The following is a description of a gene set: from publication Toyota M, Suzuki H, Sasaki Y, Maruyama R, Imai K, Shinomura Y, Tokino T (PMID 18519671) Altered expression of microRNA (miRNA) is strongly implicated in cancer, and recent studies have shown that, in cancer, expression of some miRNAs cells is silenced in association with CpG island hypermethylation. To identify epigenetically silenced miRNAs in colorectal cancer (CRC), we screened for miRNAs induced in CRC cells by 5-aza-2'-deoxycytidine (DAC) treatment or DNA methyltransferase knockout. We found that miRNA-34b (miR-34b) and miR-34c, two components of the p53 network, are epigenetically silenced in CRC; that this down-regulation of miR-34b/c is associated with hypermethylation of the neighboring CpG island; and that DAC treatment rapidly restores miR-34b/c expression. Methylation of the miR-34b/c CpG island was frequently observed in CRC cell lines (nine of nine, 100%) and in primary CRC tumors (101 of 111, 90%), but not in normal colonic mucosa. Transfection of precursor miR-34b or miR-34c into CRC cells induced dramatic changes in the gene expression profile, and there was significant overlap between the genes down-regulated by miR-34b/c and those down-regulated by DAC. We also found that the miR-34b/c CpG island is a bidirectional promoter which drives expression of both miR-34b/c and B-cell translocation gene 4 (BTG4); that methylation of the CpG island is also associated with transcriptional silencing of BTG4; and that ectopic expression of BTG4 suppresses colony formation by CRC cells. Our results suggest that miR-34b/c and BTG4 are novel tumor suppressors in CRC and that the miR-34b/c CpG island, which bidirectionally regulates miR-34b/c and BTG4, is a frequent target of epigenetic silencing in CRC. Genes down-regulated in HCT116 cells (colon cancer) upon expression of MIR34B or MIR34C microRNAs. species: Homo sapiens Human Gene Set: TOYOTA_TARGETS_OF_MIR34B_AND_MIR34C, and this is the list of marker genes: FAM234B, RIF1, CKAP2L, CASKIN2, RAD51, PPP6R2, ZMYND19, SPDYE3, CSPP1, ADISSP, C6orf89, METTL15, HSPD1, HPCA, MPHOSPH9, CHST12, FOXRED1, KRIT1, NUP58, PRKAG1, DCLRE1C, PPIP5K1, PRPF19, MBOAT2, PHTF2, MAPT, ARL13B, TMEM18, HMGN4, CENPE, BCCIP, SNU13, DPY19L1P1, CWC25, PARPBP, RFC3, DDX39B, NAV1, CNPY3, TEF, SRSF10, HDAC8, NEDD1, HYLS1, TCF7L2, STRBP, DENND5B, CDCA7, GALNT11, RAB3D, KLHL23, SLC7A11 (solute carrier family 7 member 11), ZNF681, ALMS1, C2CD2, ARHGAP11A, FEN1, RFXAP, TEX261 (NCBI Gene Id 113419), ARID1A, RTKN2 (rhotekin 2), NCOR1, SNORD22, ZNF695, SUV39H1, SREK1IP1, WDR36, RFC2, MELK, TRMT61A, HCN3, SHQ1, CCNA2, FAR1, POP1, NUFIP1, ZC3H13, KMT5A (NCBI Gene Id 387893), PLK1, MUSTN1, SHLD2, HAUS6, GRK3, SAMD1, XRCC2, TSR2, TFDP1, TAGLN2, MTARC1, MET, HOOK1, CENPF, JADE1, SRSF4, ATAD5, MSH5, TNPO3, ATPSCKMT, MIS18A, ANP32B, SF1, PPARGC1B, AFG3L2, ABHD2, SLC35A4, RAN, KAT7, MTERF2, PHLDB2, RIOK1, HNRNPA3, FAR2, LHFPL2, BARD1, CENPJ, MSL1, CEP72, HDAC6, SLC16A14, TMEM200B, EIF2S2, API5, TRIP13, CDK4 (cyclin dependent kinase 4), PRR22, MED28, CEP152, HNRNPUL1, POLR1E, L2HGDH, FIGNL1, DBF4B, RAVER2, RAD54L2, TNFRSF21, TMED4, LUC7L, CMTM1, BRI3BP, RAD54L, AURKB, DIDO1, BUB1B, SKA1, UNG, KLHDC4, ADCK2, KIF15, FAM81A, RAB31, MYB, PABPC4, TICRR, DTL, BRD10, ZNF623, CENPO, EIF5A, ZBTB8A, KMT5B, PPP4R1, SMPD4, MPHOSPH8, SUN2, MZT2B, DCTN5, UGT8, FUT8-AS1, ILF3, NECAP1 (NCBI Gene Id 25977), STK38L, TTLL4, SACM1L, BGLAP, SPC24, HAUS4, LYPD6, SH3GLB2, MANEAL, LINC00390, MTG2, PDE7A, IDH3B, BORA, NFATC3, PARM1, PKMYT1, GTF2I, FOXM1, MCU, XPO5, PTPN3, BCAP29, NECTIN1, POLE (DNA polymerase epsilon, catalytic subunit), RCC1L (NCBI Gene Id 94293), NUSAP1, NSD3 (nuclear receptor binding SET domain protein 3), AGAP4, LRP11, WWP2, SLC25A19, ZNF254, CCDC93, CC2D1A, KIF2C, PDXDC1, FLOT1, HNRNPD, ANKLE2, SYNE2, CDCA2, KIF11, MORN4, MLLT1, METTL9, FGFRL1, NFKBIB, ZBTB20, CENPA, FANCD2, MTCL2, MDN1, UGGT2, ZNF551, MCM3, ZNF639, PA2G4, PRELID2, LIG1, WEE1, DIAPH1, PDRG1, LRRC8C, TCF19, BCO2, XPO6, MANEA (NCBI Gene Id 79694), LDHA, LMAN2L, POGK, ZNF107 (zinc finger protein 107), KIF20B, ZNF273, OXCT1, CPSF6, SHMT1 (NCBI Gene Id 9316), NEK2, C18orf54, GNPDA1 (NCBI Gene Id 9930), USP5, TRA2A, PRRG4, FUS, SLC30A3, RAP1GAP, REEP4, VPS45, PLK4, GTSE1, RAPGEF6, ERP29, DNM1L, ZNF473 (NCBI Gene Id 92653), SHPRH, TUBB (NCBI Gene Id 95295), PFN2, UBE2S, H4C4 (H4 clustered histone 4), ESPN, DHX9, KIF4A, GPSM2, SCAF4, CCDC9, LY6E, ARL17A, THAP12, COPS7B, ENAH, BMP6, SMAD2, CLSPN, ERLIN1, SNX17, BPNT2, NOP56, TSEN54, ARHGDIA, PTP4A2, TUBE1, MED22, PSME3, COLGALT1, ARHGAP19, MIR100HG, ABCF1, SHCBP1, ZNF85, TOMM40, MAP3K21, TUBGCP3, CCT6P1, SNHG7, NEDD4, SLC29A1, BFAR, GEN1, MDM4, PAN2, IQCC, GPR19, TSPAN18 (NCBI Gene Id 90139), DCAF1, PARN, MARVELD3, BRIP1, LPCAT1, CEP85, VTI1A, BMPR1A, LPCAT2, C4orf46, MIR9-1HG (MIR9-1 host gene), SMIM7, GOLM1, FIP1L1, MKI67, ZMYND8, M6PR, RBBP4 (NCBI Gene Id 91125), PSIP1, NOL10, AP5B1, SKP2, MIOS, FUT10, HNRNPAB, SLC35B4, RPL23, PSMC3IP, CCNF, ATP2A2, CDC25A, KIFC1, PHGDH, SACS, ASF1B, SETD2, FGFBP3, ARAF, TMEM97 (NCBI Gene Id 27346), POLD3, SNHG17, KPNB1, PPAN, RNASEH1, ITFG2, STIL, ARHGAP32, MCM8, RAB3IP, RPIA, VOPP1 (NCBI Gene Id 81552), LRRC37A4P, MRE11, HELLS, NDC1, MMS22L, PITHD1, DDX21, PRR15L, ESR1, DESI2, LMNB1, BDNF, FAM192BP, RRM2, FAM215B, HASPIN, FAM72D, ARHGEF26, HNRNPA3P1, MIS18BP1, PSRC1, UTP23, ZNF91, KIF14, NUP210, GUSBP11, B4GALT3, LRRC37A2, PASK, NSD2, EMC3-AS1, TMEM109, CALML4, GINS3, GPR157, USP14, TBC1D5, SNRNP48, ZNF202, FASTKD2, DHFR, MYBL2, CCNB1, CDON, FAM171A1, PCBD2, ANAPC7, COQ2 (NCBI Gene Id 27235), HECTD2, PIGX, TRIM33 (tripartite motif containing 33), XRCC6, ZNF141, JADE2, SLC43A3, ZNF700, VPS54, MIEF1, ZNF488, UPF2, RAD51D, MRRF, SAP30L, DLST, AURKA, MFSD13A, DIPK2A, MLKL, CANT1, POM121, YWHAZ, POMK, DENR, RIC8B (RIC8 guanine nucleotide exchange factor B), RBM17, NRGN, ZNF544, CCNE2, APH1A, SNRNP70, ZNF493, MNS1, CRTC3, PATJ, PPFIA1, RNF145, STAG1, DMBX1 (diencephalon/mesencephalon homeobox 1), DNA2, C1orf21